Given this list of marker genes RASSF8, SPIB, ITGA11, CHMP1B, PIGV, IL1RAPL1, EDN2, SLC25A12, GPBP1L1, FNBP1, NRP2, MLLT11, RASAL2, USP9X, BDNF, LYPD1, SAMD7, RPS21, CLDN8, PCSK2, MYH4, CHML, RHOQ, CLDN4, SMARCA2, GPATCH11, PRPS1L1, PTGR3, RBM4, LRATD2, HCAR3, TBR1, SPRR1B, TRIM37, CHST7, MIR137HG, RRBP1, USP5, RAB3IP, THRA, CHST15, CBX4, ZIC2, CFL2, JARID2, TLR8, KMT2E, ARF6, PRKAG1, CD55, SLC24A1, NREP, NXN, SOBP, HOXC4, LARS1, NOL4, ASCL2, RBBP4, SLC12A1, HNRNPR, CA8, MAP2K3, PDGFB, SLC44A4, TNS2, XK, EP300, RARB, CSNK1E, FOXP2, CRLS1, PPP1CB, ZBTB20, ROGDI, FST, SULF1, CASK, SPTLC2, AFF2, FCER1G, MAOA, CLOCK, SLC36A2, CSDE1 (NCBI Gene Id 7812), EIF4A1, ZNF470, HOXB9, MRPL24, AQP9, PPP1R14C, ZBTB8OS, AP1S2, LMO4, MITF (NCBI Gene Id 7487), CUEDC1, FIGN, TBC1D16, RESF1, OTX1, BCL6, LONRF3, FRMD5, KLK3, RHOBTB2, CBX6, SERPINA7, TXLNG, GPR85, F5, HHIP, TRIB1, TOB1 (NCBI Gene Id 10140), PLA2G4A, MYL1, ANKS1B, OSMR, SLC6A5, GAREM1, RC3H2, MAP2K6, FBN2, SKIDA1, KCNJ13 (NCBI Gene Id 619535), ID3, ZEB1, NR2F2, NR0B2, MYO1C, CDC42SE1, MBNL1, PUM2 (pumilio RNA binding family member 2), EN1, KCNJ2, ARRDC3, SP8, LINC00114, XPR1, CTDSPL2, ASAH2, IL19, S100A2, CACNB2, NEK10, SP3, FAM91A1, GYS1, STN1, EHF, HTRA4, ADRB2, JPH1, C2CD5, SSH3, NPVF, STC1, MSH5, CHM, KIF2B, CDKL5, ERLIN1, SERTAD4, CLINT1, NRXN3, CALML4, TNFSF13B, MTTP, HOXB7, PLPP5, NFAT5, EGFR, SLC16A12, PROS1, CCDC71L, OTX2, MCTP1, TCF7L1, CADM1, CRIM1, COL13A1, ANGPT2, GYPC, SALL1, TSC22D1, NDUFA4L2, CD109, SIAH3, CALR, TNR, ARHGEF38, ARID1B, RPA3, S1PR1, FOXN3, TTC22, MEIS2, SYNJ1, NOTCH1, CLVS1, SYNCRIP, GPC4, SPRED1, ARNT, SCML1, FSTL1, TBX6, SIRPA, MOSPD2, SEPTIN14, LUC7L3, NCKAP5, SFRP2, COLEC10, DLX1, PDP1, FBXO11, PCDHA11, PDE4D, HCAR2, B2M, FBXW7, PRDM1, SHKBP1, UBE2E2, SMAD6, CADM3, MXI1, RB1CC1, HTR2C, TSPYL2, KDM6A, ARRDC4, ONECUT2, H3-3B (H3.3 histone B), ARHGEF6, TRIM8, RUVBL2, DEFB1, CIPC, LHX6, SBSN, PPP3CB (NCBI Gene Id 5532), CLUH, SORBS2, WNT10B, SYT16, TNFSF11, FES, SLC6A15 (solute carrier family 6 member 15), RGN, WNT5A, USP34, SOX11, RAB30, LEMD2, ESR1, here is a description of the gene set: Genes having at least one occurrence of the motif NNATTRCNNAANNN in the regions spanning 4 kb centered on their transcription starting sites. This matches the CEBPA transcription factor binding site V$CEBPA_01 (v7.4 TRANSFAC). Human Gene Set: CEBPA_01 studied in species Homo sapiens